The following is a description of a gene set: Neighborhood of GNB1 Human Gene Set: MORF_GNB1 Neighborhood of GNB1 guanine nucleotide binding protein (G protein), beta polypeptide 1 in the MORF expression compendium species: Homo sapiens, and this is the list of marker genes: UQCRC1, PARK7, KXD1, PRKDC, CLPP, CS, ARPC2, HNRNPUL1, FAM168B, CDK2, KHDRBS1, GUSB (glucuronidase beta), ADD1, TIMM17A, RNPEP, PTP4A2, HCFC1, SREBF2, DUT, FBXW11, POM121, GAK, PKN1, PRPF8, POLR2A, TIAL1, PSMB2, NUP188, EPRS1, U2AF1, HCCS (holocytochrome c synthase), CCNI, CDC16, DEK, SH3BGRL, EIF3K, HNRNPR, ASXL1, RMND5A, KHSRP, WDR1, GPAA1, CTBP1, DIAPH1, EIF4EBP2, TMED9, UBE2S, AFG3L2, RUVBL2, TARDBP, TRA2B, TERF1 (telomeric repeat binding factor 1), ATXN10, GOT2, HDAC2, SMARCC1, HNRNPA2B1, VPS26A, HADHB, DNAJC8, PTPRA, SNX3, LANCL1, NONO, NSD2, DNMT1, LYPLA1, SSB, R3HDM1, UPF3A, HNRNPC, STMN1, PDXDC2P-NPIPB14P, EIF3H, PRPF31, ATXN2L, SUMO2, STK24 (NCBI Gene Id 8428), RHEB, ACP1, RAD23A, SAFB, NDUFS5, RTCB, SEPTIN7, THOP1, NCL, IMMT, LSM2 (NCBI Gene Id 57819), VDAC1, RBBP4 (RB binding protein 4, chromatin remodeling factor), IFRD1, CSK, HDAC1, SSBP1, HNRNPM, SDHB, YWHAQ, H2AZ1 (NCBI Gene Id 3015), ESD, DDX39B, KIFC1, MAP3K11, PGK1, LRPPRC (leucine rich pentatricopeptide repeat containing), ATP6AP1, ANAPC5, HNRNPU, TARS1, TMEM123 (transmembrane protein 123), ERP29, MLEC, ESPL1, XRCC5, TREX2, MGRN1, GANAB, XPO7, SNRNP200, HNRNPAB, FUS, PABPN1 (poly(A) binding protein nuclear 1), RNF4, DDX49, BAZ1B, UQCRH, SNRPE, MTDH, MAPRE1, PDHB, EIF3D, ATP5PO, NDUFC1, DOCK3, SRP14, PRPF40A (pre-mRNA processing factor 40 homolog A), IDH3B (NCBI Gene Id 3420), PTGES3, G3BP2, SDHA, BAZ2A, H2AZ2, UBE2L3, PRRC2C, CAPZA1, NDUFS4, TRAK1, CHD4, DCTD, TUBA3C, CCT7, MCM6, MCFD2, PTBP1, UBA2, TOMM70, PPP1CC, UQCRFS1, AHCYL1, NDUFA7, NDUFS2, SLC25A3, ELOVL5, PAPSS1, CAPRIN1, COPE, TOMM20, SEC63, SRSF9, EIF4H, PCMT1, BAG6, POLA2, SLC35E2A, EDC4, MTCP1, MDC1, CAMKK2, ARIH2, DKC1, NDUFV1, TNPO3, VAMP3, HADH, MCM2, PDIA6, PPIF, GNB1, NCOR2, TCP1, GNG5, SNRPA, RTN4, NRDC, ANP32A, ACTR2, RRM1, MPHOSPH9, VDAC3, OXA1L, JTB, RBMX, HAX1, IDH3G, TYMS, DDX19A, PUM2, CALM3, PRPS2, RPIA (ribose 5-phosphate isomerase A), ILF2, ARPC3, GPN1, PPIE, TXLNA, AKR7A2 (NCBI Gene Id 94395), HADHA, POLR2C, MAP2K2, LSM7, ACTR3, BMI1, MDH1, BUB3, RNPS1, CAP1, CBX3, AP3D1, NUDC, FH, TM9SF2, STARD7, TAX1BP1, SRSF2, SET, CLSTN1, SMARCC2, CBFB, PPP2R1A, TRIM28, CTDNEP1, UBE2J1, BRD8, ILF3 (NCBI Gene Id 54783), RO60, PSMB7, USP1, GTF2A2, AP3S1, SLBP, SMNDC1, DNAJC9, AK2, EI24, PSMA1, UBE2D2 (NCBI Gene Id 7322), IARS1 (isoleucyl-tRNA synthetase 1), MTREX, CALM2, YARS1, PIN1, EIF1AX, HNRNPD, MYDGF, MRPL9, DDX19B, SF3A2, XPO1, SERP1, IMPDH1, TUFM, SRP72, CSNK2B, ATP5MC3, DGKZ, TEX261, XPO6, ATF4, EIF3I, ZNF131, DDOST, SUGP2, TXNL4A, SRRM1, GARS1, RNF44, EIF3M, RPN1, TMED5 (transmembrane p24 trafficking protein 5), PABPC4, PHB2, DR1, DYNLL1, TCEA1, SF3A1, GNB2, TRAPPC3, VDAC2, PPM1G, PTDSS1, SEC24C, PPT1, SND1, NUDT1, DGUOK